Given this list of marker genes SHCBP1L, FBXO5, AURKA, SIRT2, HSPA2, RPS6KA2, SKA2, BORA, RSPH1, TUBB8, CNTRL, KASH5, MAPK15, ASPM, SKA3, SEPTIN1, INCENP, here is a description of the gene set: Human Gene Set: GOCC_MEIOTIC_SPINDLE species: Homo sapiens A spindle that forms as part of meiosis. Several proteins, such as budding yeast Spo21p, fission yeast Spo2 and Spo13, and C. elegans mei-1, localize specifically to the meiotic spindle and are absent from the mitotic spindle.